The following is a description of a gene set: species: Homo sapiens Human Gene Set: EPPERT_LSC_R Genes up-regulated in functionally defined leukemic stem cells (LSC) from acute myeloid leukemia (AML) patients. Xenograft studies indicate that some solid tumors and leukemias are organized as cellular hierarchies sustained by cancer stem cells (CSCs). Despite the promise of the CSC model, its relevance in humans remains uncertain. Here we show that acute myeloid leukemia (AML) follows a CSC model on the basis of sorting multiple populations from each of 16 primary human AML samples and identifying which contain leukemia stem cells (LSCs) using a sensitive xenograft assay. Analysis of gene expression from all functionally validated populations yielded an LSC-specific signature. Similarly, a hematopoietic stem cell (HSC) gene signature was established. Bioinformatic analysis identified a core transcriptional program shared by LSCs and HSCs, revealing the molecular machinery underlying stemness properties. Both stem cell programs were highly significant independent predictors of patient survival and were found in existing prognostic signatures. Thus, determinants of stemness influence the clinical outcome of AML, establishing that LSCs are clinically relevant and not artifacts of xenotransplantation. from publication Eppert K, Takenaka K, Lechman ER, Waldron L, Nilsson B, van Galen P, Metzeler KH, Poeppl A, Ling V, Beyene J, Canty AJ, Danska JS, Bohlander SK, Buske C, Minden MD, Golub TR, Jurisica I, Ebert BL, Dick JE (PMID 21873988), and this is the list of marker genes: SETDB1, CDK12, SLC9A7, ZFP30, PNPLA4, RABGAP1, ARPP19, SNHG20, ZBTB39, FRMD4B (FERM domain containing 4B), EEF1AKMT3, LRRC61, CDIP1, NIPAL2, RBPMS, LRRC8B, PPP1R10, ARL3, CLN5, PLCH1 (NCBI Gene Id 23007), ABCG1, ATXN7L3B, UBR5, ARFGEF1, TGIF2, NF1, PPIG, PTCD2, IQGAP2, KLF3-AS1, TRAF3IP2, ZNF304, ZNF500, C2CD2, CSDE1, NAB1, ADGRG1, MAP3K7, VGLL4, EIF2S3, ATP1B1, PAQR6